Given this list of marker genes Vim, mt-Rnr1, Cyb5r3, Icam1, Rps12, Rps21, Sbno2, Aqp1, Gimap6, Rn7sk, Tshz2, Lrg1, Gng11, S100a16, Flt1, Tagln2, Actn4, Nherf2, Ly6a, Igfbp7, S100a13, Serinc3, Ramp2 (receptor (calcitonin) activity modifying protein 2), Plpp3 (phospholipid phosphatase 3), Mmrn2, Hspa1b, Sparcl1, Cav1, Tmem176b, Ly6c1, Ptms, Emcn, Egfl7, Tmem88, Clic1, Rps3, Rpl26, Fxyd5, Rpl30, Id1, Irf1, Tspan13, Ifitm3, Hsp90aa1, Rpl18 (ribosomal protein L18), Rps27, Tm4sf1, Calm1, Selp, Plvap (NCBI Gene Id 84094), Id3, Zfp36, Tgm2, Arl4a, Rpl38, Epas1, Tmem252, Cdh5, Rgs16, Cd9 (CD9 antigen), Tmsb4x, B2m, H2-K1, Pecam1, Nfkbia, Pdlim1, H2-Q7, Dynll1, Fkbp1a, Tsc22d1, Hspb1, Adgrf5, Rps29, Rps20, Hspa1a, Rps7, Rab11a, Ehd4, Iigp1, Elk3 (NCBI Gene Id 319474), Kdr, Ctla2a, Tmem176a, Pltp, Ly6e, Ptprb, Ier3, Socs2, Crip2, Eng (endoglin), Snx3, Ptma, Klf2, Hes1, Atp1b3, Ddit4, Gnai2, Slfn5, Hsp25-ps1, Hspa8, Socs3, Psmb8, Sptbn1, Cd200, H2-D1, Pim3, Plpp1, Cebpd, Podxl, Abcg2, Cd93 (CD93 antigen), Dusp2, Thbd, Junb, Rasip1, Rpl11, Scarb1 (NCBI Gene Id 52288), Hsp90ab1, Clec2d, mt-Rnr2, Rpl36a, Ecscr, Esam, Fam110d, Adamts1, Aopep, Atf3, Son, Rps24, Clu, Timp3, Nfkbiz, Msn, here is a description of the gene set: Mouse Gene Set: ZHANG_UTERUS_C6_ENDOTHELIAL_PLVAP_HIGH_CELL species: Mus musculus Table S2: Representative genes of each cell cluster from publication Zhang L, Long W, Xu W, Chen X, Zhao X, Wu B (PMID 35669188)